The following is a description of a gene set: Mouse Gene Set: GOMF_PYRUVATE_DEHYDROGENASE_ACTIVITY Catalysis of the oxidative decarboxylation of pyruvate. species: Mus musculus, and this is the list of marker genes: Pdha2, Pdhb, Dld, Pdhx, Pdha1, Dlat